Given this list of marker genes Ednra, Tbx18, Shox2, Nog, Mesp1, Bmp10, Tbx3, Popdc2, Tnnt2 (troponin T2, cardiac), Gata6, Wnt2, Tbx5, Prox1, Eng, Zic3, Isl1, Nkx2-5, Myh6, Trex1, Pitx2, Bves, here is a description of the gene set: species: Mus musculus The process whose specific outcome is the progression of cardiac muscle of the atrium over time, from its formation to the mature structure. Mouse Gene Set: GOBP_ATRIAL_CARDIAC_MUSCLE_TISSUE_DEVELOPMENT